Given this list of marker genes P2RY12, P2RX4, CSF1, CX3CR1, STAP1, TREM2, CX3CL1, CCL3, here is a description of the gene set: The orderly movement of a microglial cell from one site to another. Human Gene Set: GOBP_MICROGLIAL_CELL_MIGRATION studied in species Homo sapiens